The following is a description of a gene set: Genes down-regulated in comparison of dendritic cells (DC) stimulated with R848 at 2 h versus DCs stimulated with LPS (TLR4 agonist) and R848 for 2 h. from publication Napolitani G, Rinaldi A, Bertoni F, Sallusto F, Lanzavecchia A (PMID 15995707) Human Gene Set: GSE2706_R848_VS_R848_AND_LPS_2H_STIM_DC_DN species: Homo sapiens Toll like receptors (TLRs) sense microbial products and initiate adaptive immune responses by activating dendritic cells (DCs). Since pathogens may contain several agonists we asked whether different TLRs may synergize in DC activation. We report that in human and mouse DC TLR3 or TLR4 potently synergize with TLR7, TLR8 or TLR9 in the induction of selected cytokine genes. Upon synergistic stimulation, IL-12, IL-23 and Delta-4 are induced at levels 50-100 fold higher than those induced by optimal concentrations of single agonists, leading to enhanced and sustained TH1 polarizing capacity. Using microarray analysis we show that only 1.5% of the transcripts induced by single TLR agonists are synergistically regulated by combinations of TLR4 and TLR8 agonists. These results identify a combinatorial code by which DCs discriminate pathogens and provide (suggest) a rationale to design adjuvants for TH1 responses. Series_overall_design: 3 untreated, 3 treated with LPS at 2h, 3 treated with LPS at 8h, 3 treated with R848 at 2h, 3 treated with R848 at 8h, 3 treated with LPS + R848 at 2h, 3 treated with LPS + R848 at 8h, and this is the list of marker genes: TARP, ESM1, FOXS1, CXCL11, PELI1, RIGI, LINC00158, SHROOM2, SCARNA17, SPINK1 (serine peptidase inhibitor Kazal type 1), OTUD1, MASTL (microtubule associated serine/threonine kinase like), ARRDC3, DGCR5, PTGS2, SMCO3, IL1A, GBP1, CYS1, GBP5, RAB12, SUN2, MIA3, ZNF80, HERC5, ACOD1, LINC01097, PMAIP1, SLC12A1, ATXN7L2, EGR1, RPS6KC1, POFUT1, IFITM1, ISG20, CXCL2, CXCL3, LUM, CXCL8, SHBG, FLT3LG, TDRD7, HAPLN3, SOCS3, SLAMF7, IL15RA, RBBP6, KLK11, PRDM1, DGKE, GPRC5C, PLEKHF2, RNF149, ANKS4B, KIF20A, ZNFX1, IL1B, FXYD6, GBP2, NR4A3, DUSP6, ATXN7L1, IFIT1, CCK, CSRNP1, TLCD3A, ERICH1, DDX60, LMOD3, DLK2, STAT2 (signal transducer and activator of transcription 2), IFNB1, TPO, KLF4, CECR9, IL10, CCRL2, PPP1R15A, CDKN2B, SMARCA5, SNORD89, SELENOK, PCDHB18P, GCGR, IL12RB2, OSR2, MAP4K4, TTLL10, CD69, CCL5, IQCD, PLA1A (phospholipase A1 member A), BCL2A1, ENSG00000293232, IFIH1 (NCBI Gene Id 64135), PLEKHA7, SH3GL2, SYN3, RGMB-AS1, TNFAIP3, CHRNA5, PSG4, MIR155HG (MIR155 host gene), IDO1, GNGT1, JAG1, CPEB2, DNMT3L, DHX58, BEND7, ANKEF1, PIK3AP1, CBX2, ZNF503, C2orf15, ZC3HAV1, CNGB1, TNF, FAM111A, TENT4A, HERC6, NAMPT, NCOA7, IFIT2, IFIT5, IL12A, CRLF2, HCAR3, CPS1 (NCBI Gene Id 1373), OASL, IFNL1, PTOV1-AS1, ESRP1, SLC1A3, TMEM79, COL15A1, ZXDA, IFIT3, HS3ST3B1, GTF2B, ADA (adenosine deaminase), BHLHE22-AS1, TYRP1, PPM1K, NEK1, DOK6, TNIP3, DNAJB4, SLC25A28, SOD2, IRAK2, AMOTL1, KIF23-AS1, VCPIP1, NOCT, RIT2, RSAD2, C4BPA, TNFSF15, FAM43A, DYNLT2B, MCL1, KLF6, INHBA, IFI44, HES4, ITGB8, DIRAS1, CXCL9, CITED2, PTX3, CCL20, GCH1, STARD5, TNFAIP6, TAP1, TLX3, ISG15, AIM2, HRH2, CFB, C19orf73, GLIS3-AS1, TSPEAR, RHOV, TRIM26, TLR8-AS1, RNF19A, AKR1B10, EGR3, SLC28A2